Given this list of marker genes HSPA1B, SMAD7, RNF180, ARAF (NCBI Gene Id 369), ZFAND2A, ZNF418, NOP53, SGTA, USP9X, RNF139, BBS7, NFE2L2, TGFB1I1, PANO1, MTOR, RPS7, UBXN1, USP7, ATXN3, BAG6, AKT1, CSNK2A1, GBA1, PTEN, CSNK1D, HECTD1, FZR1, MAP1A, CEBPA, KEAP1, TRIB3, PLK3, CDK5RAP3, TTC36, TRIB2, CAV3, RBX1, CHFR, MAPK9, DET1, PSMD10, KLHL40, FOXF2, STUB1, SENP1, COMMD1, ELOB, ZYG11B, HSP90AB1, DAB2, PRKN, RACK1, RYBP, STYX (serine/threonine/tyrosine interacting protein), FBXW7, UCHL5, TLK2, GSK3A, RAD23B, USP26, NUB1, TAF1, ZER1, GABARAP, CSNK1A1, PLK1, BAG2, LATS1, CSNK1E, UBQLN4, GCLC, USP14 (NCBI Gene Id 9097), PSEN1, CBFA2T3, LRRK2, HIPK2, DVL1, FHIT, DNAJB2, HAMP, SUMO1, DESI1, GNA12, IL33, UBE2K, CDC20, UBE3A, CSNK2B, PTK2B (protein tyrosine kinase 2 beta), SOCS4, CDK2, GIPC1, WNT1, RPL23 (ribosomal protein L23), SUMO2, AURKA, AGTPBP1, SHH, CDKN2A, FBXW8, SH3RF2, TF, XPO1, PHF20L1, IKBKG, TRIB1, TRAF7, PABIR1, TMEM168, SUFU, HERPUD1, RPL5, OGT, SIRT6, PBK, PIAS1, CDC20B, SMURF1, SH3RF1, CAMLG, AXIN1, CSNK2A2, RAD23A, N4BP1, CLU, PRICKLE1, LAPTM5, PABPN1L, MDM2, USP38, DDA1, GSK3B, AXIN2, USP5, TRIM39, CCAR2, L3MBTL3, RFPL1, VCP, GLMN, AGBL4, TAF9 (TATA-box binding protein associated factor 9), ARHGAP5-AS1, COP1, RPL11, HSPBP1, UFL1, NKD2, MTM1, BAG5, EGF, PML, HSPA1A, SIRT2, TRIM67, PDCL3, CCDC22, PAQR3, SMARCC1, HFE, FBXO22, PYHIN1, RCHY1, DDRGK1, PTK2, SIRT1, PRMT6, WAC, WNT10B (Wnt family member 10B), PARK7, QRICH2, SH3RF3, SOCS5, BCAP31, DISC1, EIF3H, here is a description of the gene set: Human Gene Set: GOBP_REGULATION_OF_UBIQUITIN_DEPENDENT_PROTEIN_CATABOLIC_PROCESS species: Homo sapiens Any process that modulates the frequency, rate or extent of ubiquitin-dependent protein catabolic process.